The following is a description of a gene set: species: Homo sapiens An abnormality of the pericardium, i.e., of the fluid filled sac that surrounds the heart and the proximal ends of the aorta, vena cava, and the pulmonary artery. Abnormal pericardium morphology Human Gene Set: HP_ABNORMAL_PERICARDIUM_MORPHOLOGY, and this is the list of marker genes: SLC12A3, IFIH1, PTPN14, PRKAG2, PLVAP, DPH5, SMAD4 (SMAD family member 4), IRAK1, DNASE1L3, UBAC2, GATA6, LCK, FAT4, HBA2, ENPP1, ACADVL (NCBI Gene Id 37), EIF2AK4, PRG4, ADAMTS3, PTPN22, DNASE1, ERAP1, FCGR2B, IL6, DOCK11, STAT4 (signal transducer and activator of transcription 4), ALG9, FCGR2A, TREX1, ITK, CTLA4 (NCBI Gene Id 3411), HLA-DPB1, SAT1, CDH23, TSC2, HLA-DPA1, P4HA2, LETM1, MAF, PMM2, ABCC9, CCR1, RNU7-1, MIF, IL23R, HBA1, EPHB4, MYBPC3, IRF4, PPP1R13L, CALCRL, IL12A, FAS (Fas cell surface death receptor), PRTN3, HLA-DRB1, LMNA, TCTN2, NF1, MEFV, TRIM37, C4A, AEBP1, MTO1, TSC1, UQCRFS1, LACC1, BLTP1, TNFRSF1A, IFNGR1, CLCNKB, MYRF, IL10, GBA1, IL12A-AS1, TLR4 (NCBI Gene Id 7099), NOD2 (NCBI Gene Id 8135), ABCC6, SPP1, KLRC4 (killer cell lectin like receptor C4), LYST, HLA-B, CCBE1, MCM10